Given this list of marker genes INPP4B, PIK3C3, MTMR2, MTMR12, PIK3C2A, PIKFYVE, INPP4A, FIG4, PI4K2A, MTMR10, MTMR4, INPP5F, MTM1, PIK3R4, PI4K2B, VAC14, here is a description of the gene set: species: Homo sapiens At the early endosome membrane, phosphatidylinositol 3,5-bisphosphate (PI(3,5)P2) is generated in two steps from phosphatidylinositol 3,4-bisphosphate PI(3,4)P2 by the action of various kinases and phosphatases. part of: PI Metabolism Reactome Pathway: Synthesis of PIPs at the early endosome membrane